The following is a description of a gene set: Human Gene Set: WANG_BARRETTS_ESOPHAGUS_DN To investigate the relationship between Barrett's esophagus (BE) and esophageal adenocarcinoma (EAC), we determined gene expression profiles of discrete pathological stages of esophageal neoplasia using a sequence-verified human cDNA microarray. Fifty one RNAs, comprising 24 normal esophagi (NE), 18 BEs, and nine EACs were hybridized to cDNA microarrays. Five statistical analyses were used for the data analysis. Genes showing significantly different expression levels among the three sample groups were identified. Genes were grouped into functional categories based on the Gene Ontology Consortium. Surprisingly, the expression pattern of BE was significantly more similar to EAC than to NE, notwithstanding the known histopathologic differences between BE and EAC. The pattern of NE was clearly distinct from that of EAC. Thirty-six genes were the most differentially modulated, according to these microarray data, in BE-associated neoplastic progression. Twelve genes were significantly differentially expressed in cancer-associated BE's plus EAC (as a single combined tissue group) vs noncancer-associated BE's. These genes represent potential biomarkers to diagnose EAC at its early stages. Our results demonstrate that molecular events at the transcriptional level in BE are remarkably similar to BE's-associated adenocarcinoma of the esophagus. This finding alarmingly implies that BE is biologically closer to cancer than to normal esophagus, and that the cancer risk of BE is perhaps higher than we had imagined. These findings suggest that changes modulated at the molecular biologic level supervene earlier than histologic changes, and that BE is an early intermediate stage in the process of EAC. Genes down-regulated in Barrett's esophagus compared to the normal tissue. studied in species Homo sapiens from publication Wang S, Zhan M, Yin J, Abraham JM, Mori Y, Sato F, Xu Y, Olaru A, Berki AT, Li H, Schulmann K, Kan T, Hamilton JP, Paun B, Yu MM, Jin Z, Cheng Y, Ito T, Mantzur C, Greenwald BD, Meltzer SJ (PMID 16449976), and this is the list of marker genes: NFE2L2, AQP3, FMO2, JUP, OVOL1, STK24, GPNMB (glycoprotein nmb), PRCP, GSTA4, FGFR3, S100A8, KLK7, CUL3 (NCBI Gene Id 8452), DSG1, ACTR3 (NCBI Gene Id 10096), ARF5, KLK6, EMP2, SERPINB1, SPRR3, PLP2, KLF5 (KLF transcription factor 5), LTA4H, CTSB, ALDH9A1